Given this list of marker genes CALML4, CORO2B, C15orf61, MIR629, CARS1P1, PAQR5, NOX5, LINC02205, ENSG00000207119, RNU6-1 (NCBI Gene Id 26827), SENP8, RPS24P16, ANP32A (NCBI Gene Id 8125), UACA, KIF23-AS1, HNRNPA1P5, RPL5P3, MAP2K5, SALRNA3, NR2E3, TMEM202, SPESP1-NOX5, RNU6-745P, SPESP1, LINC02204, PAQR5-DT, HMGN2P40, ENSG00000301330, EIF5A2P1, TLE3, KRT8P9, CLN6, DRAIC, ITGA11, HMGB1P6, GEMIN8P1, MIR4312, RPL17P39, THSD4 (NCBI Gene Id 79875), ENSG00000294920, LARP6, CT62, KIF23, HEXA-AS1, RPL12P35, RPL29P30, RPL21P115, FEM1B, RPLP1, RNA5SP399, SALRNA2, MYO9A, EWSAT1, MAP2K5-DT, SKOR1, ENSG00000261460, CELF6, LINC03137, GLCE, LRRC49, HEXA, PKM, LINC02896, IQCH (IQ motif containing H), ENSG00000261632, AAGAB, SKOR1-AS1, IQCH-AS1, PARP6, GRAMD2A, PIAS1, RNU2-65P, THSD4-AS1, THAP10, here is a description of the gene set: Human Gene Set: chr15q23 species: Homo sapiens